The following is a description of a gene set: species: Homo sapiens Human Gene Set: GOCC_SIDE_OF_MEMBRANE A cellular component consisting of one leaflet of a membrane bilayer and any proteins embedded or anchored in it or attached to its surface., and this is the list of marker genes: ABCB1, IL7R, ENOX1, HLA-DPA1, BTNL10P, CCRL2, GPC3, ART1, OTOA, CD177 (CD177 molecule), FCGR2C, AP2A2, FGA, OPCML, LAG3, THBS1, RHOA, GNG2, KLRC3, GNAL, PLEKHA4, ALG10B, RS1, CNTFR, ITGB6, RAET1G, HM13, GFRA4 (GDNF family receptor alpha 4), CD24, IL6R, PTEN, LY9, FGB, CHUK, FCER1A, LYPD4, TNFRSF9, FGF8, GFRA1, TGM3, GEM, HFE, BDH1, FES, ALG13, BECN1, IL12RB1, FCGR1A, ITGA5 (integrin subunit alpha 5), GPC6, RGMB, FCN1, ALG14, MPL, SMPDL3B, AMBP, MS4A2, CDH1, LITAFD, DTNA (NCBI Gene Id 86552), PCSK9, BTN3A1, DPEP1, PRND, MDGA1, ACE, IL1R1, SPA17, PDCD1, CTSB, CNTN1, CLEC4G, TFRC, ACKR3, CLEC17A, BCAP31, EPM2A, PLAU, HLA-DPB1, EPHA5 (EPH receptor A5), SLC2A4, CYLD, MIEN1, IL12RB2, SYAP1, CLCN3, RPS28, F2, GPC1, NRN1L, FRMD6, PKD2, CD1E, LDLRAP1, BTN1A1, HLA-DQA1, QTRT1, CD160, CXCR4, ITGA11, SPAM1, VNN2, TFPI, ASTN1, CCR5, CSF2RA, ITPR3, CARMIL2, FASLG, CUBN, EFCAB7, MICB, ESYT2, GFRA3, BORCS8, DNAJB2, C17orf99, GNAO1, CLEC2A, GPC2, RTBDN, SLC4A3, GHR, GNAI1, HLA-DRB1, GNB5, PTP4A1, CEACAM8, FCGR2B, ADAM9, GNG5, CANX, FCER2, KCNQ1, TRAF2, LY6D, CD1C, BST2, IL11RA, SPPL2A, ADA, VNN1, CCR6, NCAM1, OSMR, BCAM, ITGA3 (NCBI Gene Id 4454), CCR1 (NCBI Gene Id 1230), MAP2K2, FCGRT, EEF1A1, PRSS41 (serine protease 41), ICOSLG, IGSF21, IL1RL1, SNAPIN, HLA-DRB3, ADAM29, BTN2A3P, KIT, BCAN, SELP, NLRP10, CD200R1, CXCR3, MS4A1, ANTXR1, EFNA3, GPC5, ANK1, CXCR5, GNA13, PRLR, TH, ADAM21, AJAP1, GNG7, SEMA7A, FCRL4, FARP1 (NCBI Gene Id 10160), HLA-DRB4, LYPD2, FKBP1A, CD109, BIRC2, RASGRP4, SCNN1G, ITLN1, DSG1, ACKR4, IL9R, IL4R (interleukin 4 receptor), P2RX7, LYPD6, CD209, CD1A, PRSS42P, SAMD12, CHMP4B, FAS, CA4, NDUFAF5, SLAMF7, CD34, NCF1, SNX18, LY6G6C, ENPP6, CLEC4A, CLEC10A, RACGAP1, PLG, CCR2, ALOX15, B4GALT1, CDH13, BTN2A1, FOLR2, MBL2, ALG12, CD14, NTSR1, CLEC4D, ANPEP, IQGAP1 (IQ motif containing GTPase activating protein 1), HLA-F, ACP1, GNG14, CD200R1L, HJV, ITGB3, CCR9 (C-C motif chemokine receptor 9), ALPP, EPN3 (NCBI Gene Id 55040), ABCC4, JAK2, BTNL9, FOLR1, ITGAM, DAG1, GNG10, NOA1, CD69, BORCS6, DNAJC19, LRRC24, ATP6AP2, HLA-H, CPM, GNB2, CALR, ADGRA3, AP2A1, PLAUR, GNAT3, CD226, CCR3, CCR7, LYPD1, PTPN3, BTN3A3, GP1BA, TRGV1, LITAF, ICAM1, TNFRSF11A, HLA-A, HLA-DQA2, LDLR, NRCAM, FCRL1, ABCA1, ITGA9, ITGB2, CDK16, FOLR3, GNA14, RTN4R, IL5RA, MTSS2, AP2M1, AMOT, HEG1, NEGR1, GNAT1, LY6G6D, PKP4, KCNAB1, LY6H, CPO, ENTPD1, TLR4, ALG6, CCR8, GNG11, TNFRSF10C, ESYT3, GNG13, ULBP3, CD36, ALG3 (NCBI Gene Id 131416), ALPL, SPPL3, BORCS7, TRAF3, AKAP5 (A-kinase anchoring protein 5), GNAZ, GRIA1, IL13RA1, ATP1B2, CXCL10, CD9, BMPR1A, ITGA2B, CYTH1, CD59 (NCBI Gene Id 966), PALM2AKAP2, RGS8, CHMP4BP1, PAM16, ABCG1, IL2RB, RAB5A, TGFBR2, GNA12, PECAM1 (platelet and endothelial cell adhesion molecule 1), MOG, KLRC4, PRSS21, SNX5, SLAMF1, LY6K, PRSS55, STAC, S1PR1, CHMP7, CD248, TEX101, PRMT8, LYPD5, PGM5, TRGV4, LILRB1, ERMAP, JAK3, LY6G5C, LY75, FADD, GRK2, CHRNA4, CD8A, LYN, ULBP1, TAS2R16, SPTB, CSF2RB, MYZAP, LRP2, FCRLA, UMOD, COLEC10, FCER1G, CNTN4, ITGA6, IL31RA, BTNL2, RGS2, SPACA4, TMEM123, TNFRSF4, SPRN, LYPD6B, CCR4, PALM, TRGV5, FCRL3, FCGR3B, MYD88, CD22, RGS1, TREH, IL6ST, DPEP3, CD19, SLC4A1 (NCBI Gene Id 8158), AQP2, CXCR2, TRGV2, GML, CD83, CD40LG, EFNA1, GNGT1, SLC38A1, CD3E, P2RX1, ITGA7, XCR1, MTSS1, ALG5, GNAT2, EPM2AIP1, GNGT2, HLA-DRA, ANXA5, ALPG (NCBI Gene Id 251), GPC4, GNG8, AP4B1, ANTXR2, SOCS3, HLA-DRB5, SYT6, XPNPEP2, MILR1, THBD (thrombomodulin), FERMT2, HSPA8, CD84, ALG2 (ALG2 alpha-1,3/1,6-mannosyltransferase), KLRD1, CRLF1, ITGAL, HID1, NT5E, ROBO4, BTN2A2, SERPINA5, ENOX2, CD163L1, MCF2L, CD1D, JUP (NCBI Gene Id 3728), SLAMF6, THADA, IL13RA2 (NCBI Gene Id 3598), GNA11, CLEC14A, PTPN7, AP2B1, CNTN5, SPTA1, TNFRSF18 (TNF receptor superfamily member 18), CTLA4, SCUBE1, GNB4, KRAS, CEACAM21, OMG, TRAF5, BST1 (NCBI Gene Id 683), RPL27, CDH5 (NCBI Gene Id 1003), HYAL2, ITGA10, CFP, FRMD1, KLRC1, GFRAL, GNB3, KCNIP1, CD163, MFGE8, ALPI, ALG8, FCRLB, MAP3K5, CD27, CD4, RTN4RL1, CD5, CLEC4F, GNAI3, LILRB4, HLA-G, TNFRSF14, MDGA2, LY6E, S100A6, CD79B, CXCL9, G6PD, IL2RA, PTPN4, ACHE, FER, CD207, CD244, HHLA2, CXCR6, ECE1, HLA-E, GM2A, CD48, SPPL2C, GNG3, ART3, GSR, KLRC2, B2M, PRNP, INSR, STAB2, SLC22A11, TRGC1, TRGV9, CLPTM1, VTCN1, CEACAM6, GNG5B, CD3G, RPS29, NTNG2, EFNA4, LY6L, CD79A, PKHD1, FGG, FCRL2, EPOR, TYK2 (tyrosine kinase 2), QTRT2, BLOC1S2, MUC16 (NCBI Gene Id 94025), KDR, GPHN, OTULINL, PTPRC, CSF3R, NTM, LYPD3, BLOC1S1, FCGR3A, CD33 (CD33 molecule), GNB1, MSLN, STAC3, RTN4RL2, SLAMF9, SELL, AQP4, PTPN22, AP2S1, GNAQ, ITGAV, SHROOM4, BTN3A2, TNF, ART4, CLEC4E, DNAI2, RAET1E, ST14, RASAL3 (NCBI Gene Id 64926), CD274, CCR10, BTNL8, TECTA, CD86, IKBKB, DPEP2 (dipeptidase 2), OSBPL2, CACNB4, PDCD1LG2, GNRH1, GLRA1, CD55, PLET1, CNR2, ADAM30, GPIHBP1, CAPN2, PDGFRA, LYNX1, SCNN1B, AZGP1, TGFBR3, FCN2, MYH10, CD28, ITGAX, ABCG2, RNF31, PTPN1, FCRL6, MR1, ASPSCR1, BORCS5, MELTF, TCN2, CD1B (CD1b molecule), TRGV10, SCNN1A, CLEC4C, IL23R, GNG12, ITGA2, SLC7A5, ITGAE, FCN3, RPS26, MICA, CLEC12B, ADGRE1, IL21R, CEACAM7, ENPP3, EFNA2, CDIP1, CXCR1, ENPEP, EFNA5, GBP5, PPP3CA, ATP2C2, FCRL5, LSAMP, ITGAD, TRGC2, RAET1L, FLOT1, MYH9, GAS1, TAPBP, SPPL2B, VCAM1, CX3CR1, F3, LIFR, CD80, ACKR2, KLRK1, PPP1R9B, DNAJA1, GFAP, KLRC4-KLRK1, NTNG1, ALCAM, CD52, CNTN2, CNTN3, IL3RA, TRAF3IP2, IL17A, CHMP4C, HLA-B, ITGA8, HLA-C, KCNJ3, LAMP1, RASA3, LY6S, COA8, TLR8, GLIPR1L1, COLEC11, TECTB, GNA15, ALG9 (ALG9 alpha-1,2-mannosyltransferase), CLEC4M, MMP17, RECK, THY1, LY6G5B, TRGV3, ITGA4, FCGR1BP, GNG4, CTSK, BTNL3, JAK1, TRPM8, GNAS, CNTN6, RAB21, CTSA, ASGR1, F10, NRN1, C2CD2L, MUC17, CRIPTO, IZUMO1R, CHMP4A, HLA-DQB1 (major histocompatibility complex, class II, DQ beta 1), ASGR2, CHRNB2, KCNAB2, LRRK2, CD2, IL2RG, CD40, SELE, CLEC6A, ENG, DNAJA3, APP, SPN, SDC1, TNFRSF13C, MMP25, CD276, SAMD10, ITGB1, ITGA1, LCT, STAC2, UMODL1, TMC1, RGMA, EEF1A2, DLG1, ULBP2, MICALL1 (MICAL like 1), TFR2, TRGV8, CEACAM5, MCAM, LYPD8 (NCBI Gene Id 648444), CD74, NPHS2, CLEC2D, TIRAP, IDE, LEPR, TRAF6, HCK (NCBI Gene Id 3055), DIABLO, GP2, GFRA2, GRIA2, ADAM20, HTRA2, CRLF2, ALG1, HLA-DQB2, IL13 (NCBI Gene Id 96500), GNAI2, CD3D, FCGR2A, P4HB, TRADD, PSCA, CFC1, KXD1, CXCL12